The following is a description of a gene set: Human Gene Set: MIR6831_3P from publication Chen Y, Wang X (PMID 31504780) species: Homo sapiens Genes predicted to be targets of miRBase v22 microRNA hsa-miR-6831-3p in miRDB v6.0 with MirTarget v4 prediction scores > 80 (high confidence targets)., and this is the list of marker genes: IRF2BPL (NCBI Gene Id 64207), PAIP2, TMEM199, CD200, IL1A, COPS2 (NCBI Gene Id 9318), CNOT7, ASH1L, ZNF45, ETNK1, CCDC73, GRIA2, SLC22A4, RASGRP1, ZNF17, RB1, METTL8, APAF1, PRICKLE1, BTG3, PRKG1 (protein kinase cGMP-dependent 1), LRBA, PIN4, SMG7, SOX5, SYNC, RAD21, NDUFA4, SCOC, PXK, TMCO3 (transmembrane and coiled-coil domains 3), ZNF397, YY1, SCHIP1, BTC, IGF1, RTKN2, ABAT, CFAP69, ZBTB20, MACROD2, KIF21A, KAT6B, BICD2, TIFA (TRAF interacting protein with forkhead associated domain), PDCD4, TMEM132B, RCBTB1, MTF2, ZNF778, RNF103, NANP, BLOC1S5, NUDT5, SIDT2 (NCBI Gene Id 51092), SELENOT, IQCJ-SCHIP1, PPP4R3A